Given this list of marker genes Efemp2, Gdf5, Fn1, Itgb3, Itgb8, Tgfb2, Bmp10, Ltbp2, Tgfb3, Ltbp4, Ltbp3, Itgb6, Emilin2, Emilin3, Itgav, Fbln2, Itga8, Bmp7, Ltbp1, Bmp2, Mfap4, Vtn, Fbn1, Eln, Fbln5, Tgfb1, Itgb1, Mfap5, Emilin1, Mfap2, Fbn2, Bmp4, here is a description of the gene set: Molecules associated with elastic fibres Mouse Gene Set: REACTOME_MOLECULES_ASSOCIATED_WITH_ELASTIC_FIBRES studied in species Mus musculus